The following is a description of a gene set: studied in species Homo sapiens Muscle weakness affecting the tibialis anterior muscle. Human Gene Set: HP_TIBIALIS_MUSCLE_WEAKNESS Tibialis muscle weakness, and this is the list of marker genes: TTN, MTRFR, LRP12, GNE, DYSF, NOTCH2NLC, GIPC1, RILPL1